Given this list of marker genes Tsc2, Hmga1, Tsc1, Htatip2, Rint1, here is a description of the gene set: Mouse Gene Set: MP_INCREASED_UTERUS_LEIOMYOMA_INCIDENCE studied in species Mus musculus from publication Motenko H, Neuhauser SB, O'Keefe M, Richardson JE (PMID 26092688) Mouse genes annotated to increased uterus leiomyoma incidence (MP:0003570) retrieved from the Mouse Genome Informatics database via MouseMine